Given this list of marker genes Atp5mc1 (ATP synthase membrane subunit c locus 1), Mmp8, Gzmc, Kcnk13, Comtd1, Ankrd55, Pla2g12a, Slc7a2, Prelid1, Wdr83os, Pbld1, Angptl6, Vamp5, Vamp8, Tmsb15a (thymosin beta 15a), Ifrd1, Bcl2l15, Higd1a, Itpk1, Metrnl, Lamtor4, Ftl1, Nudt8, Tarm1, Hk2, Socs1, Ccdc184, Il1a, Tmsb10, Npc2, Med28, F10, Angpt2, Dtnbp1, Ccl3, Mlkl, Nos2, Gal, Treml1, Zfp524, Gzmd, Rabac1, S100a13, Tmem35b, Cend1, Tmem205, Dhrs7b, Snx18, Fabp5, Prss46, Gzmf, Tnfrsf8, Nagk, Gzmg, Smim40, Ctdp1, Arg1, Prf1, Pi4ka, Ccl24, Ndufa2, Il11ra1, Gstm1, Mt1, Evl, Tmem178, Tent5c, Clec1b, Psmb10, Fam98c, Hilpda, Pgls, Atp6v1f, Fau, Flii, Ppp1r15a, Cstb, Hmox1, Ogfod3, Rhov, Borcs6, Tmem160, Hcfc1r1, Pin4, Cdkn1a, Ifitm6, Acod1, Rex1bd, Sertad1, Ptgir, Ciao2b, Gnl1, Zswim7, Cyba, Gzma, Gpr157, Cdc42ep2 (NCBI Gene Id 68573), Grcc10, Anpep (alanyl aminopeptidase, membrane), Snx8, Usp50, Keap1, Ifi27 (interferon, alpha-inducible protein 27), Trafd1, Vcf1, Rab33a, Mmp12, Car4, Pard6a, Npy, Fcor, Atp6v0d2, Il13, Uqcrb, Brk1, Eif1b, Cltb, Slc66a2, Chil3, Ccl6, Fam162a, Ccl1, Insrr, Guca1a, Gadd45g, Fam241a, Ccdc124, Cyb5a, Idnk, Ndufa13, Cyp4v3, Psmb6, Eif4ebp3 (eukaryotic translation initiation factor 4E binding protein 3), Mfsd5, Osm, Batf3, Pim3, Coq8b, Vps37d, Mif, Bcl2a1b, Cst7, Mlycd, Bdh2, Ubd, D8Ertd738e, Ndufb4, Ctsd, Akr1a1, Lyrm1, Rnaset2a, Igflr1, F7, Ccl4, Bola1, Blvrb, Gzme, Atp5mf (NCBI Gene Id 80395), Prr15, Apln, Ctsz, Pde6g, Tnfrsf26, Ogfod2, Hcar2, Fcrl6, Vps28, Kxd1, Gmfg, Ltb4r1, Gzmb, Pop7, Tmem202, Pf4, Rilpl2, Ctsg, Pcdhgc4, Btbd16, Klrg1, Npb, Slc39a2, Card19, Dhrs1, Trem2, Garin1a, Tmem50a, Slc41a3, Ndufs6, Hlx, Nfil3, C4b, Lman2, Cox7c, Tnfrsf9, Leprotl1, Pdcd1lg2 (programmed cell death 1 ligand 2), Ninj1, Gp1bb, Srgn (serglycin), Zdhhc14, here is a description of the gene set: Metagene derived from the post-Immune checkpoint blockade treated samples. Significance of the post-ICB sample metagenes was not discussed in the study. Most patients with cancer are refractory to immune checkpoint blockade (ICB) therapy, and proper patient stratification remains an open question. Primary patient data suffer from high heterogeneity, low accessibility, and lack of proper controls. In contrast, syngeneic mouse tumor models enable controlled experiments with ICB treatments. Using transcriptomic and experimental variables from >700 ICB-treated/control syngeneic mouse tumors, developed a machine learning framework to model tumor immunity and identify factors influencing ICB response. Projected on human immunotherapy trial data, found that the model can predict clinical ICB response. further applied the model to predicting ICB-responsive/resistant cancer types in The Cancer Genome Atlas, which agreed well with existing clinical reports. Mouse Gene Set: ZENG_GU_POST_ICB_METAGENE_22 species: Mus musculus from publication Zeng Z, Gu SS, Wong CJ, Yang L, Ouardaoui N, Li D, Zhang W, Brown M, Liu XS (PMID 36240281)